Given this list of marker genes UQCRFS1, NDUFAB1, ATP5ME, ATP6V0D1, ATP6V1D, SDHB, MTHFD2, MRPL12, SLC25A5, CYP11B2, ATP5PF, HSPE1, NDUFB7, SURF1, NME4, COX5B, GATD3, TIMM17B, CLPP, ATP6V1H, VDAC1 (NCBI Gene Id 7416), GCSH (NCBI Gene Id 2653), NDUFV2, UQCRC2, HADHA, NDUFB3, PRDX5, NDUFA6, ATP5F1E, NDUFA3, NDUFA2, ATP6V1E1, BCKDHA, ACAA2, NDUFA5 (NADH:ubiquinone oxidoreductase subunit A5), ATP5F1A, CKMT1B, ATP5MC1, HADH, DECR1, NDUFA9, CLN3, COX6C, COX4I1, NDUFS4, MGST1 (NCBI Gene Id 4257), ECH1, ATP6AP1 (ATPase H+ transporting accessory protein 1), ATP6V0B, NDUFV1, ATP5MF (NCBI Gene Id 9551), CYBA, NDUFS5, UCP1, COX6B1, ATP6V1B2, COX5A, ATP5MC3, COX6A1, UQCRC1, IDH3B, COX7A2, SDHD, NDUFB10, ATP5F1D, NDUFB5, ATP5PD, MAOB (NCBI Gene Id 4129), COX8A (cytochrome c oxidase subunit 8A), AGXT, ACADVL, ATP5MJ, SLC25A3, NDUFS8, NDUFA7, NDUFB1, COX17, SCP2, UQCR11, FH (fumarate hydratase), NDUFS6, NDUFS3, UQCRQ, GPX4, ATP2C1, LACTB, SDHA, ATP6V0E1, NDUFB8, SUCLG1, SSBP1, SLC39A6 (NCBI Gene Id 25800), ABCF1, GOT2, COX7B, BNIP3L, UQCRB, GLUD1, IDH2, ECHS1, ATP5F1C, NDUFA1, CYCS, PCK2, ATP6V0A1, ATP6V1F, ATP6V1G1, ATP5PO, TRAP1, AMT, BNIP3, CYC1, ALAS1, ATP5F1B (ATP synthase F1 subunit beta), NDUFA4, PCCB (propionyl-CoA carboxylase subunit beta), HAX1, NDUFS2, ATP6V0C, COX7C, MRPL3, UQCRH, COX7A1 (NCBI Gene Id 1346), TOMM20, here is a description of the gene set: Oxidative phosphorylation and ATP synthesis. Human Gene Set: MODULE_152 species: Homo sapiens